The following is a description of a gene set: Human Gene Set: MIR375_3P from publication Chen Y, Wang X (PMID 31504780) studied in species Homo sapiens Genes predicted to be targets of miRBase v22 microRNA hsa-miR-375-3p in miRDB v6.0 with MirTarget v4 prediction scores > 80 (high confidence targets)., and this is the list of marker genes: SPOCK1, POC1B, SEC23A, SPINK13, XAF1 (XIAP associated factor 1), ZIC1, CREBZF (NCBI Gene Id 58487), ATXN7, ELAVL4, ZBTB20, SLC16A2, MMD, QKI, APBB2, CDKN2AIP, WBP1L, HNF1B, DIP2C, LPAR4, KLF5, SPAG9, RNF139, LDHB, POU3F1, HOXD3, ITPRID1, GOLPH3, MUC15, PLEKHA3, RLF, USP32, RBPJ, UBE3A, CENPM, TSC1, NFIX, SOCS5, ZFP36L2, POU2AF3, KCNAB1